The following is a description of a gene set: from publication Amit I, Garber M, Chevrier N, Leite AP, Donner Y, Eisenhaure T, Guttman M, Grenier JK, Li W, Zuk O, Schubert LA, Birditt B, Shay T, Goren A, Zhang X, Smith Z, Deering R, McDonald RC, Cabili M, Bernstein BE, Rinn JL, Meissner A, Root DE, Hacohen N, Regev A (PMID 19729616) Human Gene Set: GSE17721_PAM3CSK4_VS_CPG_4H_BMDC_DN mouse primary BMDCs were stimulated with tlr ligands and gene expression changes were profiled on Affymetrix arrays Genes down-regulated in comparison of dendritic cells (DC) stimulated with Pam3Csk4 (TLR1/2 agonist) at 4 h versus DC cells stimulated with CpG DNA (TLR9 agonist) at 4 h. studied in species Homo sapiens, and this is the list of marker genes: STK26, TRA2A, MED14, RGS2, COCH, CDK14, GBP4, HEPH, VWA1, GLRX3, SERPINE1, CD274, HELZ2, ATG4D, CLASP2, TENT2, RARS1 (arginyl-tRNA synthetase 1), GAB2, OTUB1, MYCBP, PURA, CEPT1, TNFSF9, LMO7, STK39, MXD1, EXOSC9, HACD4, WASHC4, PMEPA1, AKT3 (AKT serine/threonine kinase 3), ATP5IF1, P2RY12, EVI2A, PIM1, DBNL, IRF8, COPG2, PLEKHG6, CLN3, SMR3A, PSME2, IL10RA, MMP9, NONO, ARHGEF40, PTGS2, AIM2, CNP, SLIRP, PLA1A, LMO2, CHMP5, TXLNG (taxilin gamma), RNPC3, ZFYVE26, ATG9B, PTGDS, RPH3A, RRAGC, BCKDHB, SLC12A9, C11orf68, EPSTI1, WARS1, CPSF4L, APTX, HBEGF, IFI27L2, MET, SPOP, STX8, FBXW11, VMA21, F13A1, TUT7, ETS1, CCL13, TRIM26, UBL7, KAT6A, ITM2B, CCDC65, KYNU, HINFP, TIAM1, RMDN3, ZNF281, LAMA5, SP7, SNCAIP, SVBP, CH25H, KLF2, CCNL2, RAB3IP, POU3F1, MB, IRF1, FGD4, ELAVL2, ENY2, ANKRD6 (ankyrin repeat domain 6), TFG, HTRA1, BLOC1S4, KAT2B, SPPL2A, ATAD1, HLA-E, SST, CD40, EDN1, TCTN2, IDO1, TREX1, ECE2, ARL4A, GTPBP2, MOV10, ZNF444, VRK2, TOR3A, EHD4, IRF9, MAP2K1, CLIC4, ISG15, RNF214, ZBP1, TIMELESS, NUB1, RUFY3, TACR1, KDR, ELF5, SRD5A2, PFN2, ARF4, LTB4R, BID (NCBI Gene Id 637), TAP2, CTSG, PSME4, MESP2, STARD8, ST6GALNAC4, ZBTB8A, CCL24, ST3GAL1, VRK1, PGS1, PCDH15, SPTLC2, ENPP4, RASD1, CRISPLD1, IRF2, CYSLTR2, KRT82, MS4A6A, GCA, ATP10A, MYD88, CAB39L (NCBI Gene Id 81617), NDUFS4, SERPINB2, GPATCH1, SYNJ2BP, NAT1, CACNG1, TLR8, KRT2, CCNJ, SOX14, PSMB9, BLTP1, CPTP, ALDH7A1, INAVA, ADGRG1, CYP27A1, B3GNT2, LRRC8C, PTPRR, PADI3, DGKA, LRRK2, ITPR1, DNAJA1, LLGL1, GNMT, TNFSF8, KYAT3, PLIN2, ARL6IP1, CPT1A, USP9X, ATP13A1, TMEM229B